The following is a description of a gene set: RUNX3 binds to Runx response elements in the distal (P1) promoter of the RUNX1 gene, repressing RUNX1 transcription. Reactome Pathway: RUNX3 regulates RUNX1-mediated transcription studied in species Homo sapiens part of: Transcriptional regulation by RUNX3, and this is the list of marker genes: RUNX3, CBFB, RUNX1